The following is a description of a gene set: The process whose specific outcome is the progression of the glomerular basement membrane over time, from its formation to the mature structure. The glomerular basement membrane is the basal laminal portion of the glomerulus which performs the actual filtration. species: Mus musculus Mouse Gene Set: GOBP_GLOMERULAR_BASEMENT_MEMBRANE_DEVELOPMENT, and this is the list of marker genes: Mpv17, Nid1, Sulf1, Nphs1, Lamb2, Ext1, Col4a3, Wt1, Col4a4, Myo1e, Sulf2